The following is a description of a gene set: studied in species Homo sapiens Genes having at least one occurence of the motif GTAAACC in their 3' untranslated region. The motif represents putative target (that is, seed match) of human mature miRNA hsa-miR-299-5p (v7.1 miRBase). Human Gene Set: GTAAACC_MIR2995P, and this is the list of marker genes: ERC2, INPP5A, ZFX, TNPO1 (NCBI Gene Id 3842), ETF1, ATG5, ROBO1, MAFG, NAV3 (neuron navigator 3), UBE2J2, CALU, MECP2, CPEB2, TEAD1, TSPAN2, MYF6, GOLGA1, SRSF7, MAT2A, FAR1, HDAC4, ABCD3, SOX4, IPO13, BAGE2, SGK1, HSPA2, PUM2, PPP2R5A, SIAH1, FOXG1, RSBN1, TCEAL8, PATZ1, CS, PURB, RAP2C, H3-3B, PHF12, ABR, CAB39, TIPARP, MDGA2, MAP3K8, CTCF, CNOT3, DALRD3, DLX2